Given this list of marker genes Rfc4, Rfc2, Rfc3, Dscc1, Chtf18, Chtf8, Rfc5, Ddx11, here is a description of the gene set: species: Mus musculus A heptameric complex related to replication factor C, which loads the DNA polymerase processivity factor proliferating cell nuclear antigen (PCNA) onto DNA and plays a vital role in chromosome cohesion. In Saccharomyces the subunits are known as Ctf18p, Rfc2p, Rfc3p, Rfc4p, Rfc5p, Dcc1p, and Ctf8p. Mouse Gene Set: GOCC_CTF18_RFC_LIKE_COMPLEX